The following is a description of a gene set: studied in species Mus musculus Binding to a receptor that possesses protein tyrosine kinase activity. Mouse Gene Set: GOMF_RECEPTOR_TYROSINE_KINASE_BINDING, and this is the list of marker genes: Crkl, Grb2, Cblc, Gab2, Pcna, Eif3a, Fiz1, Ntrk2, Pik3r1, Map3k7, Rasgrf1, Cpne3, Sh2b3, Pspn, Fnta, Nrtn, Ptpn14, Pitpnm2, Frs3, Gdnf, Tiam1, Arhgef16, Irs2, Dnaja3, Crk, Irs1, Dazap2, Angpt2, Grb14, Cblb, Shc1, Cbl, Ptpn11, Frs2, Stap1, Sh2d3c, Nrg1, Shc2, Shc4, Flt3l, Alkal1, Ptprf, Erbb2, Gfral, Trp53, Angpt1 (angiopoietin 1), Rasa1, Acp4, Sh2b1, Lrp4, Pik3r2, Ptpn2, Hyal2, Nr3c1, Socs5, Pitpnm3 (NCBI Gene Id 327958), Dock4, Shc3, Myoc, Artn (NCBI Gene Id 11876), Plcg1, Cd2, Pitpnm1, Rack1, Ptpn1, Tradd, Ywhag, Zpr1, Mst1 (NCBI Gene Id 15235), Angpt4, Anxa5, Nck2, Elmo2, Cadm4, Dusp3, Sh2b2, Dok2, Rnf41, Itgax, Nck1, Tob1, Alkal2, Gas6